The following is a description of a gene set: Alternative complement activation species: Mus musculus Mouse Gene Set: REACTOME_ALTERNATIVE_COMPLEMENT_ACTIVATION, and this is the list of marker genes: Cfd, C3, Cfb (NCBI Gene Id 14962), Gzmm, Cfp